The following is a description of a gene set: Formation of the beta-catenin:TCF transactivating complex species: Mus musculus Mouse Gene Set: REACTOME_FORMATION_OF_THE_BETA_CATENIN_TCF_TRANSACTIVATING_COMPLEX, and this is the list of marker genes: Ruvbl1, Trrap, Lef1, Pygo2, Bcl9, Tle1, Tle2, Tcf7l2, Tcf7, Ep300, Tcf7l1, Kmt2d, Hdac1, Leo1, Tle3, Ash2l, Pygo1, Smarca4, Tert, Tle4, Ctnnb1, Men1, Cdc73, Rbbp5, Bcl9l, Kat5